Given this list of marker genes Fcgr3, Timd5, Icam5, Hspa8, Syt7, Abr, Fcer1g, Ptx3, Myo1g, Megf10, Lyar, Il2rb, Treml4, Dock2 (dedicator of cyto-kinesis 2), Rab34, Alox15, Ifng, Cdc42, Trem2, Tusc2, Calr, Mfge8, Bcr, Colec11, Rack1, Lep, F2rl1, Fpr2, Washc5, Timd4, Elane, Sirpa, Fgr, Dnm2, Cd302, Unc13d, Marco, Fcgr1, Stap1, Tulp1, Letmd1, Rab27a, Colec10, Myo7a, Appl2, Sftpd, Myo18a, Fpr-rs6, Tub, Cebpe, Ncf4, Rab14, Anxa3, Rab20, Elmo3, Abl2, Arhgap12, Anxa11, Prtn3, Clec7a, Btk, Ccr7, Pip5k1c, Adgrb1, Gsn, Aif1, Nckap1l, Rab5a, Klrh1 (killer cell lectin-like receptor subfamily H, member 1), Ptk2, Ptprj, Camk1d, P2ry6, Il15ra, Coro1c, 4933434E20Rik, Lepr, Msr1, Ticam2, Nos2, Tafa4 (NCBI Gene Id 320701), P2rx7, Tlr4 (toll-like receptor 4), Tyro3, Fpr-rs3, Slc48a1, Rab11fip2, Ano6, Il15, Itgam, Nfix, Itgal, Sftpa1, Fcgr2b, Cfp, Thbs1, Ager, Pros1, Tgfb1, Tgm2, Bltp1, Sod1, Abca1, Axl, Cdc42se2, Gulp1, Dysf, Elmo1, Sphk1, Mex3b, Arap1, Lyst, Atg7, Ncf2, Slc11a1, Pikfyve, Mbl1, Mertk, Fpr-rs4, Trex1, Havcr1, Rac1, Rab7, C2, Psg22, Hmgb1, Pecam1, Plscr1, Arl8b, Knl1, Cd300a, Myd88 (NCBI Gene Id 17874), Xkr7, Timd2, Rap1a, Fcer2a, Pycard, Srpx, Prkcg, Xkr4, Irf8, Cd300lf, Scarb1, Vav1, Dppa1, Apoa2, Xkr6, Elmo2, Mbl2, Atg3, Siglece, Rapgef1, Ighg1, Slamf1, Apoa1, Rab39, Lman2, C4bp, Cd209b, Cdc42se1, Itgb1, Colec12, Tlr2, Becn1, Gas6, Mst1r, Clcn2, Csk, Pik3ca, Sh3bp1, Fpr-rs7, Zp3r, Itgav, Sirpb1a, Eif2ak1, Ptprc, Itgb2, Pparg (peroxisome proliferator activated receptor gamma), Atg5, Xkr8, Rara, Cyba, Nr1h3, Coro1a, Nod2, Abca7, Tmem175, Timd6, Appl1 (NCBI Gene Id 97938), Abl1, Pip4p2, Fcnb, Itgb3, C3, Ccr2, Ahsg, Lrp1, Jmjd6, Rab7b, Il2rg, Dock1, Itga2, Rab31, Tyrobp, Gata2, Cln3 (NCBI Gene Id 12752), Bin2, Pear1, Cryba1 (crystallin, beta A1), Tm9sf4 (transmembrane 9 superfamily member 4), Pld4, Anxa1, Adipoq, Lbp, Hck, Myh9, Cnn2, Clcn3, Cd47, Rap1gap, Syt11, Ldlr, Pten, Spon2, Mesd, Syk, Spg11, Plcg2, Ccl2, Snx3, Ighg2b, Cd36, Arhgap25, Pot1b, Pla2g5, here is a description of the gene set: Mouse Gene Set: GOBP_PHAGOCYTOSIS species: Mus musculus A vesicle-mediated transport process that results in the engulfment of external particulate material by phagocytes and their delivery to the lysosome. The particles are initially contained within phagocytic vacuoles (phagosomes), which then fuse with primary lysosomes to effect digestion of the particles.